Given this list of marker genes FEM1B (NCBI Gene Id 23374), BMP4, HOXB13, IGF1, FRS2, FGFR2, BMP7, HOXA13, ESR1, HOXD13, NKX3-1, SFRP1, SHH, here is a description of the gene set: The process in which the branching structure of the prostate gland is generated and organized. A branch is a division or offshoot from a main stem. species: Homo sapiens Human Gene Set: GOBP_BRANCHING_INVOLVED_IN_PROSTATE_GLAND_MORPHOGENESIS